The following is a description of a gene set: This event has been computationally inferred from an event that has been demonstrated in another species.<p>The inference is based on the homology mapping from PANTHER. Briefly, reactions for which all involved PhysicalEntities (in input, output and catalyst) have a mapped orthologue/paralogue (for complexes at least 75% of components must have a mapping) are inferred to the other species. electronically inferred by orthology from the curated human pathway species: Mus musculus Reactome Pathway: Gamma-carboxylation of protein precursors part of: Gamma-carboxylation, transport, and amino-terminal cleavage of proteins, and this is the list of marker genes: F2, Proz, Pros1, Bglap2, F10, F7, Ggcx, F9, Proc